Given this list of marker genes Fbll1, Fbl, Ftsj3, Gar1, Tfb2m, Zcchc4, Tsr3, Nsun3, Mrm3, Mettl5, Bud23, Fdxacb1, Rpusd2, Rpusd4, Nsun4, Emg1, Mrm2, Mettl16, Naf1, Mettl15, Tfb1m, Nop10, Nhp2, Nop2, Nsun5, Dimt1, Nat10, Mrm1, Dkc1, Trmt2b, Rpusd1, Trmt112, here is a description of the gene set: The covalent alteration of one or more nucleotides within an rRNA molecule to produce an rRNA molecule with a sequence that differs from that coded genetically. studied in species Mus musculus Mouse Gene Set: GOBP_RRNA_MODIFICATION